Given this list of marker genes CLIC3, TNN, CEACAM1, TSPAN18, MIR23A, FGF18, MIR375, FGF1, IL10, FUT1, CEMIP2, ZNF354C, PDPK1, ADGRG6, MIR221, MIR17, E2F2, TJP1, ITGA5, MIR1224, GHSR, MIR377, ALOX5, MIR34B, MIR329-1, SEMA6A, PPP1R16B, RHOJ, MIR30B (NCBI Gene Id 407030), VEGFA, MIR138-1, MIR126, MIR20A, HMGB1, STARD13, EPN1, EPN2, MIR125A, MIR34C, CREB3L1, MIR34A, GHRL, KLF4, MIR30C1 (NCBI Gene Id 407031), PKM, MIR30E, MIR92A1, JMJD8, MIR31, SYNJ2BP, MIR1-1, MIR18A, KLF2, MIR487B, FGF2, BMPER, S100A1, FGF16, JCAD, THBS1, MIR19A, SMAD1, DLL1, GLUL, PIK3CB, DSG2, JAK1, MIR495, ADAMTS9, TGM2, here is a description of the gene set: Any process that modulates the frequency, rate or extent of sprouting angiogenesis. Human Gene Set: GOBP_REGULATION_OF_SPROUTING_ANGIOGENESIS species: Homo sapiens